Given this list of marker genes TRAPPC9, HEATR3, FOXP2, SYT1, DNMT3A, CDK19, KCNK4, RNU4-2, CNOT2, COL18A1, CASZ1, EGFR, RERE, GABRD (NCBI Gene Id 2563), INTS1, DEAF1, PDPN, EBF3, ADAM17, HSPG2, MED13L, H4C5, KCNAB2, DDB1, RALGAPA1, SPEN, AHDC1, PRDM16, UBE4B, LUZP1, PRKCZ, SKI, RALA, MMP23B, GNB2, ACTB, here is a description of the gene set: An eyebrow that extends straight across the brow, without curve. species: Homo sapiens Horizontal eyebrow Human Gene Set: HP_HORIZONTAL_EYEBROW